Given this list of marker genes SOX11, RAP1B, SNPH, RNF38, GAD2, RBMS1, TMSB10, MAPKAPK2, RC3H1, CTBP1, GRID1, RUNX1T1, ZEB2, STMN2, VAPB, PPARGC1A, MEIS2, UBE2Q1, RAC1, STIM2, NSMCE4A, ERC2, HOOK3, WDR33, PPP4R4, DYRK1A, GLS2, MAT2B, YAF2, QSER1, DYRK2, FBN2, KANSL1L, PI4K2A, MAGI2, CHKA, KMT5A, PTMA, UBR3, RBM26, ZFAND5, VEZF1, SPRED2, MKX (mohawk homeobox), SEMA3C, STYX, RHOA (NCBI Gene Id 387), CLIP3, NRXN1, ARHGAP20, NRF1, CRYZL1, PTPN2, KIF21A, BMI1, ANKS1B, PDE4D, FOXK1, PLPPR1, PLCXD3, SMG1, ARID1A, ADAMTS3, RNF44, TSHZ3, SYPL1, CADM4, ENY2, MAFB, EMC7, DAGLA, TMEM30A, CREBRF, CKAP5, NLK, ATP1B1 (NCBI Gene Id 481), JAG1, SETD7, KCNMA1, GPM6A, ILRUN, PPM1A, SP3, TIMM9, MYO1B, GNB1, SOX9, KBTBD8, PTPRM, ASAP2, ADAMTS4, RETREG3, GNAI1, SP1, FMR1, HDAC4, FBXL7 (NCBI Gene Id 23194), ZNF770, PCGF3, IVNS1ABP, GDA, TRIB2, NOTCH2, PUM2, PHF1, SMPX, UBE2E3, PLSCR3, CPLX2, CDYL, RFX3, OTUD4, SNRNP40, CILK1, ZMAT1, TOP1, DTNA, CNR1, RNF220, C3orf70, NXPH1, CD2AP, PPP3R1, RBBP6 (RB binding protein 6, ubiquitin ligase), ABHD17B, GIGYF2 (NCBI Gene Id 59281), DAPK1, TBX15, ULK2, FAM222B, RNF13, PIK3C2B, ANK3, STK35, AFF4, ZIC2, PURG, CDK16, CCER1, NR3C1, SIRT1, ZMYM4, API5, RALGAPB, RNF135, AZIN1, RNF145, RUNX2, AGO2, PISD, KIAA1217, TMEM184B, GANAB, MAML3, LIN54, here is a description of the gene set: studied in species Homo sapiens Human Gene Set: TGTATGA_MIR4853P Genes having at least one occurence of the motif TGTATGA in their 3' untranslated region. The motif represents putative target (that is, seed match) of human mature miRNA hsa-miR-485-3p (v7.1 miRBase).